The following is a description of a gene set: Human Gene Set: GOCC_NURD_COMPLEX An approximately 2 MDa multi-subunit complex that exhibits ATP-dependent chromatin remodeling activity in addition to histone deacetylase (HDAC) activity, and has been shown to establish transcriptional repression of a number of target genes in vertebrates, invertebrates and fungi. Amongst its subunits, the NuRD complex contains histone deacetylases, histone binding proteins and Mi-2-like proteins. studied in species Homo sapiens, and this is the list of marker genes: HDAC2, RBBP7, MTA1, CDK2AP2, CDK2AP1, MBD3, MTA3, CHD5, CHD4, MTA2, MBD2, GATAD2B, GATAD2A, HDAC1, CHD3, RBBP4